Given this list of marker genes CRLF1, HES1, TCF21 (NCBI Gene Id 6943), GZF1, RET, BCL2, SMAD5, LGR4, TMEM59L, ROBO2, WNT11, SFRP1, SOX9, HNF1B, FGFR2, HOXB7, SALL1, ADAMTS16, CTNNB1, SPRY1, PAX8, SLIT2, AGT, EPCAM, SMAD4, FGF1, DCHS1, PBX1, SHH, HOXA11, MYC, GATA3, NPNT, SDC4, HOXD11, EYA1, WNT1, BMP7, GREM1, SMAD7, SIX1, FGF2, ZBTB16, RARA, BMP2, SMAD1, BMPER, CAT, KIF26B, CER1, ARG2, WT1, LAMA5, AGTR2, SMAD6, CITED1, FOXD1, SMAD2, WNT6, WNT2B, PKD2 (polycystin 2, transient receptor potential cation channel), RARB, GDNF, HS2ST1, ILK, WNT9B, SIX4, WNT4, SIM1, GDF11, GPC3, LHX1, TGFB1, OSR2, FOXC2, FOXJ1, PTCH1, PKD1, FGFR1, MAGED1, SMO, SIX2, NOG, FOXC1, SMAD3, PAX2, LZTS2, HS3ST3A1, OSR1, HS3ST3B1, BASP1, FGF8, REN, DLG1, TACSTD2, VEGFA, GREB1L, BMP4, SOX8, CALB1, FGF10, GLI3, CTNNBIP1, here is a description of the gene set: The process whose specific outcome is the progression of the mesonephros over time, from its formation to the mature structure. In mammals, the mesonephros is the second of the three embryonic kidneys to be established and exists only transiently. In lower vertebrates such as fish and amphibia, the mesonephros will form the mature kidney. Human Gene Set: GOBP_MESONEPHROS_DEVELOPMENT studied in species Homo sapiens